The following is a description of a gene set: Genes down-regulated in comparison of naive CD8 T cells versus effector CD8 IL2RA high T cells at. from publication Kalia V, Sarkar S, Subramaniam S, Haining WN, Smith KA, Ahmed R (PMID 20096608) CD25, the high affinity interleukin-2 (IL-2) receptor alpha-chain, is rapidly upregulated by antigen-specific CD8+ T cells after T cell receptor stimulation. We demonstrated that during an acute viral infection, CD25 expression was dynamic, and a subset of virus-specific CD8+ T cells sustained CD25 expression longer than the rest. Examination of the in vivo fate of effector CD8+ T cells exhibiting differential responsiveness to IL-2 revealed that CD25lo cells, which were relatively less sensitive to IL-2, preferentially upregulated CD127 and CD62L and gave rise to the functional long-lived memory pool. In contrast, CD25hi cells that accumulate enhanced IL-2 signals, proliferated more rapidly, were prone to apoptosis, exhibited a more pronounced effector phenotype, and appeared to be terminally differentiated. Sustained IL-2 receptor signaling resulted in increased CD8+ T cell proliferation, higher granzyme B expression and exaggerated contraction after antigen clearance. These data support the hypothesis that prolonged IL-2 signals during priming promote terminal effector differentiation of CD8+ T cells. studied in species Homo sapiens Human Gene Set: GSE19825_NAIVE_VS_IL2RAHIGH_DAY3_EFF_CD8_TCELL_DN, and this is the list of marker genes: BAX, C6orf136, GALT, SYNJ1, SRF, STK11, TSEN2, PHAF1, FANCL, INIP, MCOLN1, ING3, YDJC, SLC25A15, PIP4K2B, VPS50, RIF1, PDCD2, MTA2, RMDN1, SREBF2 (sterol regulatory element binding transcription factor 2), RNF126, MRPL19, PRMT5, RP2, SNX19, PMM1, PMS1, BTAF1, REXO1, ANGPTL4, LRWD1, MRPS7, HPSE, PCYOX1, WRAP53, ABHD14A, LSM6, SMCO4, STAP1, RCE1, PIDD1, PLEKHF1, SPG7, AGPAT2, SLC25A38, MPHOSPH9, CLN6, NAA10, RHBDF2, CHADL, HDAC4, LPCAT1, AARSD1, METTL6, ZNF707, DEXI, WDTC1, NECAP2, APLF, HDLBP (high density lipoprotein binding protein), CEP76, TNFSF14, CHAF1B, SMTN, MCM6, ATP13A2 (NCBI Gene Id 63919), DENND1B, GEMIN4, VTI1A, ATP6V0A2, RNH1, PALS2, G0S2, NFE2, MOSPD3 (NCBI Gene Id 64598), NMRK1, MYO1G, AS3MT, DPP7, EIF3B, DDX18 (NCBI Gene Id 8886), FHOD1, TRNAU1AP (tRNA selenocysteine 1 associated protein 1), PLXNC1, PSMC3, FBXO38, MED25, MBOAT7, VASP, HAUS3, SNRNP70, ARL6IP4, MYBBP1A, GARS1, TGFB1, GADD45GIP1, MTOR, MRPS18A, SCLY, NAA15, SLC35C1, RRBP1, SMDT1, ERI3, YIPF3, ZW10, RNF41, SF3A1, MRPS30, ATP8B4, ABCB7, UBXN8, RB1, VAC14, MRTFA, SLC19A2, GTSE1, CYB5R1, SUCLG2, MRPL42, AMMECR1, TRIM32, CHST12, IFI30, DOK2, AP1S1, COX6C, TMEM138, NDUFAB1, FBXO31, JMJD6, ALAS1, IL3RA, ECE2, DEK, TDP2, RFC1, LAMP1, HIKESHI, TMEM219, MOB4, MYL11, LMF2, AP4B1, VPS33B, INF2, ORC2, SAFB2, MGAT4B, MSTO1, RBBP7, SF1, GIT1, CLPTM1, SLC4A7, CAND2, TSSC4, MAN1C1, TRAPPC5, IMMP2L, PGP, PCGF5, CCDC174, VPS45, FASN, NCSTN, NUP214, HIP1, TOR2A, SYTL3, SNRNP25, STYX, ENKD1, COPS6, GOLGA2, PSMD11, AARS1, ANXA7, RAB31, PHACTR4, INTS13, NAPEPLD, POLR3C, LZTR1, MRPL4, GRK2, ENTPD1, EFL1, GTF2IRD2, TAF6, CKAP2, BRF2, TSC2 (TSC complex subunit 2), SND1, MRPL16, NBEAL2, SNAI3-AS1, PPP2R2A, IL1RL2